Given this list of marker genes MEGF8, MUL1, MTPN, ADAM10, RASAL1 (RAS protein activator like 1), BMP10, COL14A1, NDRG3, BMPR2, RACK1, HDAC6, TSPYL2, ST7L, ZFYVE27, BTG1, MYOCD, BLTP1, ING1, FGF13, CAPRIN2, SERTAD2, FAM107A, LIMK1, CCN3, CDKN2A, MIR199A1, MAP1B, SERPINE2, SESN2, MT3, SPAG9, SYT17, SMAD3, EIF4G2, CREB3, CDKN2D, CEACAM1, SIPA1, ACVRL1, TGFB2, VEGFA, PPT1, KRT17, CPNE5, OLFM1, RGS4, ARHGAP4, CDH4, CIB1, SESN1, RGS2, NME6, ADCY10, C8orf44-SGK3, RAB21, IST1, NRG1, PRKCQ, DDX3X, CRYAB, IL9, SGK2, TWF2, CDKN1A, DDR1, CDH1, NGF, TMEM97, PRSS2, CXCL12, ULK1, AVPR1A, CXCL16 (C-X-C motif chemokine ligand 16), FBP1, SOX17, BARHL2, WNT5A, INHBA, TFRC, SPHK2, CDKN2AIP, MAD2L2, TP53, TNFRSF12A, S100A8, SLIT1, RAB33B, MELTF, JADE2, MIR208A, IFRD1 (interferon related developmental regulator 1), SYT3, MINAR1, CAV3, NTRK3, CAMK2D, CLSTN1, MAP2, AGTR2, SCGB3A1, MIR19A, PTPRJ, WT1, NRG3, LMX1A, PAK4, TEAD1, NPM1, EXOSC2, GSK3B, VGLL4, DDX49, CCAR2, GSK3A, INS, POU4F2, MIR19B1, KIF14, CISH, CD38, CLSTN3, DNM2, NUBP1, RTN4, ESR2, TCHP, SLIT2, PAFAH1B1, MAG, DNAJB2, PPARD, HBEGF, CRABP2, CDC42, FN1, SMARCA4, ARHGEF11, DCUN1D3, CEP43, BDNF, F2, RYK, TOMM70, ROS1, RNF157, IGFBP5, SEMA3F, SGK1, H3-3B, HYAL2, IP6K2, TRIM46, SOCS2 (suppressor of cytokine signaling 2), SMURF1, LPAR3, INO80, HPN, SEMA4D, RPS6KA1, ENO1, TNC, BRAT1, TRIM32, CGRRF1, RNF6, GJA1, ACVR1B, EGLN2, CSNK2A1, ZNF639, ITCH, TGFBR1, MTOR, HNF4A, ADNP, NAIF1, SEMA6D, ABL1, NET1, MACF1, MEG3, ITSN2, KIAA0319, SPP1, DSCAM, YAP1, RBBP7, TAOK2, KDM2B, MMP14, GOLGA4, URI1, MSX1, LGI1, SFRP2, CDC73, IL2, PAK5, SDCBP, RIMS2, CDK5, PRKN, IL17RB, JADE3, PLXNA4, CRLF3, CACNG7, TP53TG5, DCSTAMP, KAT7 (NCBI Gene Id 63437), FHL1, SMAD4, MAP3K13, CFL1, IGFBP1, DISC1, NRP1 (neuropilin 1), PPARA, GDI1, ULK2, TAF9B, NTN1, ING4, RICTOR, HDGFL2, CDKN1B, SPART, ADAM17, KLHL22, MFSD2A, RTN4R, CDHR2, EPM2A, SEMA6C, GDF9, BCL6, EXOSC4, IGFBPL1, DIP2B, H3-5, TRPC5, RPTOR, CPNE9, MYL2, YY1, RIMS1, EPHA7, PTCH2, ARMC12, EDN1, ING5, LAMTOR2, TRIM40, PRR5, UCN, APOE, EXTL3, SLIT3, HSPA1B, CYP27B1, ANAPC2, G6PD, EBAG9, SERTAD3, GDF2, RERG, MIR199B, SMARCA2, SEMA4F, RPS6KA3, SEMA3A, NKX6-1, WNT3, PPP1R9B, CDK11A, CPNE6, NPPA, SFN, HSPA1A (NCBI Gene Id 3303), ADAM15, PI16, CLASP2, EPHX2, ATAD3A, DCBLD2, S100A9, PAK1, TTL, PRDM11, ENPP1, RUFY3, EFNA5 (NCBI Gene Id 1946, ephrin A5), CDKN2C, RASGRP2, IGFBP3, SEMA3G, EIF4G1, SFRP1, TSG101, NPPB, TNR, AKAP6, BCL11A, CRYAA, OSGIN1, DACT3, SPOCK1, CDKL3, NANOS1, UNC13A, FSTL4, SIN3A (NCBI Gene Id 25942), SLC9A1, SHTN1, ISLR2, L1CAM, PLXNA3, EI24, SUPV3L1, BST2, OSGIN2, ATG16L1, SYT1, RND2, KIF26A, CSNK2A3, ZC3H12D, CDA, HYAL1, OSTN (osteocrin), BDKRB1, TMEM196 (transmembrane protein 196), MAPT, DCUN1D5, OGFR, MEAF6, CTDP1, LAMTOR1, RGMA, BAP1, CDK11B, GNG4 (G protein subunit gamma 4), SEMA7A, PSRC1 (proline and serine rich coiled-coil 1), SLC25A33, PARP2, SGK3, WFDC1, BCL2, AVP, SLC23A2, WNT3A, CRKL, CHPT1, CYBA (cytochrome b-245 alpha chain), DERL2, CRK, SLC44A4, EAF2, BRCA1, AGTR1, LTBP4, MAPKAP1, DNPH1, BCAR1, DAB2, PAPPA2, MAP2K5, CCDC85B, DCC, EGFR, AGT, IGFBP4 (insulin like growth factor binding protein 4), CTTN, PSMD10, SEMA5A, NEDD4L, SYT4, TGFB1, SMAD7, DRAXIN, PUM2, PLAA, SRF, MLST8, HRG, H3-3A, EXOSC9, PHB1, KAZALD1, SH3BP4, TRPV2, ERBB2, NCBP1, XBP1, NRCAM, PTPRS, IGFBP7, FRZB, AKT1, PML (PML nuclear body scaffold), SYT2, IGF1, CDKL5, FOXP1, SYT14P1, STK11, SPHK1, NPR1, ACSL4, JADE1, N6AMT1, P3H1, MUC12, ADIPOR1, RB1, PABIR1, here is a description of the gene set: studied in species Homo sapiens Human Gene Set: GOBP_REGULATION_OF_CELL_GROWTH Any process that modulates the frequency, rate, extent or direction of cell growth.